The following is a description of a gene set: studied in species Mus musculus Binding to a mitogen-activated protein kinase kinase kinase, a protein that can phosphorylate a MAP kinase kinase. Mouse Gene Set: GOMF_MITOGEN_ACTIVATED_PROTEIN_KINASE_KINASE_KINASE_BINDING, and this is the list of marker genes: Map4k2, Dusp19 (NCBI Gene Id 96977), Cav2, Ppef2, Mapk8ip1, Map3k11, Trim8, Ppara, Cdc37, Tcf3, Dazap2, Sash1, Ror2, Mapk9, Map2k1, Mapk1, Marveld3, Traf2, Trim72, Dixdc1, Map2k7, Tgfbr2, Mapk8ip3, Cdc42, Stk38, Dab2ip